Given this list of marker genes SPP1, STAT4, IRAK1, SAT1, ADA2, LYN, TNFAIP3, here is a description of the gene set: Human Gene Set: HP_LUPUS_ANTICOAGULANT Lupus anticoagulant studied in species Homo sapiens Presence of lupus anticoagulant (LA) autoantibodies. LA represent a heterogeneous group of autoantibodies, IgG, IgM, or a mixture of both classes, that interfere with standard phospholipid-based coagulant tests (this is only an in vitro phenomenon, LA do not cause reduction of coagulation in vivo). The antibodies are directed against plasma proteins which also bind to phospholipid surfaces.